Given this list of marker genes FGF8, PPP2R1A, FRS2, FGF5, PPP2CA, FGF23, PPP2CB, FGF1, RPS27A, SRC, FGF9, GRB2, FGFR3, FGF18, BRAF, MAPK3, PTPN11, FGF17, UBC, MKNK1, FGF16 (NCBI Gene Id 8823), FGF20, SPRY2, UBB, CBL, FGF4, MAPK1, UBA52, FGF2, here is a description of the gene set: studied in species Homo sapiens Negative regulation of FGFR3 signaling Human Gene Set: REACTOME_NEGATIVE_REGULATION_OF_FGFR3_SIGNALING